The following is a description of a gene set: Mouse Gene Set: GOBP_GLYCOSYL_COMPOUND_METABOLIC_PROCESS The chemical reactions and pathways involving glycosyl compound. species: Mus musculus, and this is the list of marker genes: Tyw3, Urad, Slc25a51, Uox, Dguok, Mtap, Akr1c14, Akr1c21, Pycr3, Cbr4, Dctd, Akr1c18 (NCBI Gene Id 105349), Oard1, Adal, Fuca1, Ahcy, Akr1cl, Naga, Gda, Macrod2, Nt5c1a, Lcmt2 (NCBI Gene Id 329504), Akr1c20 (NCBI Gene Id 116852), Akr1b1, Gba1, Ptgdr, Pnp2, Ak1, Akr1c12, Akr1c6, Tk1, Pnp, Upb1, Qng1, Nmrk1, Trmt12, Gamt, Macrod1, Akr1c19, Ada, Nudt1, Fuca2, Tyw5, Hprt1, Enpp4, Bloc1s6, Xdh, Tymp, Tyw1, Pcmt1, Adk, Cda, Nmrk2, Icmt, Cdadc1, Upp2, Dnph1, Dck, Abhd10, Dtymk (deoxythymidylate kinase), Aprt, Nt5c1b, Pgm2, Nt5e, Gnmt, Dera, Nt5c3, Pemt, Acp3, Tk2, Urah, Dpyd, Th, Gla, Ahcyl, Nmnat2 (nicotinamide nucleotide adenylyltransferase 2), Aicda, Nt5c2, Akr1a1, Upp1, Gba2, Akr1c13